The following is a description of a gene set: Mouse Gene Set: GOCC_SODIUM_CHANNEL_COMPLEX studied in species Mus musculus An ion channel complex through which sodium ions pass., and this is the list of marker genes: Cacna1h, Unc80, Cacna1g, Scn10a, Grik1, Grik4, Scnn1a, Scn3b, Scn9a, Scn8a, Scnn1g, Scn2b (NCBI Gene Id 72821), Scn2a, Trpm4, Scnn1b, Scn5a, Scn1b (NCBI Gene Id 20266), Cacna1i, Grik5, Grik2, Scn4b, Gria4, Scn3a, Grik3, Scn1a, Scn11a, Scn4a (NCBI Gene Id 20270)